Given this list of marker genes 4933405O20Rik, Idh2, Aco2, Idh1, Idh3b, Idh3g, Idh3a, here is a description of the gene set: species: Mus musculus Mouse Gene Set: GOBP_ISOCITRATE_METABOLIC_PROCESS The chemical reactions and pathways involving isocitrate, the anion of isocitric acid, 1-hydroxy-1,2,3-propanetricarboxylic acid. Isocitrate is an important intermediate in the TCA cycle and the glycoxylate cycle.